The following is a description of a gene set: from publication Ichiba T, Teshima T, Kuick R, Misek DE, Liu C, Takada Y, Maeda Y, Reddy P, Williams DL, Hanash SM, Ferrara JL (PMID 12663442) The liver, skin, and gastrointestinal tract are major target organs of acute graft-versus-host disease (GVHD), the major complication of allogeneic bone marrow transplantation (BMT). In order to gain a better understanding of acute GVHD in the liver, we compared the gene expression profiles of livers after experimental allogeneic and syngeneic BMT using oligonucleotide microarray. At 35 days after allogeneic BMT when hepatic GVHD was histologically evident, genes related to cellular effectors and acute-phase proteins were up-regulated, whereas genes largely related to metabolism and endocrine function were down-regulated. At day 7 after BMT before the development of histologic changes in the liver, interferon gamma (IFN-gamma)-inducible genes, major histocompatibility (MHC) class II molecules, and genes related to leukocyte trafficking had been up-regulated. Immunohistochemistry demonstrated that expression of IFN-gamma protein itself was increased in the spleen but not in hepatic tissue. These results suggest that the increased expression of genes associated with the attraction and activation of donor T cells induced by IFN-gamma early after BMT is important in the initiation of hepatic GVHD in this model and provide new potential molecular targets for early detection and intervention of acute GVHD. species: Mus musculus Hepatic graft versus host disease (GVHD), day 7: down-regulated in allogeneic vs syngeneic bone marrow transplant. Human Gene Set: ICHIBA_GRAFT_VERSUS_HOST_DISEASE_D7_DN, and this is the list of marker genes: IGKV5-2, SLC25A10, HSD17B2, HBB, HES6 (hes family bHLH transcription factor 6), LIFR, ME1, POM121, PAPSS2, SLC26A1, EXOSC8, ELOVL2, UCK1, PRLR, CDC5L, IGHA2, ADGRL1, C8G, ACAA1, NXN, PKLR, HMGCS2, CYP4A11, NAT8, CYP4A22, CYP2B6, DIO1, SC5D, CELA1, ACTL7B, SERPINA6, RELN, GHR, SULT4A1, ELOVL6, G6PC1, LIPC (lipase C, hepatic type), TENM3, RPL22, PROM1, CRYL1, YJU2, ALAS2, OSBPL5, RDH16, PRM3